Given this list of marker genes RUNX1, CREBBP, CSF2, LGALS3, CBFB, PRKCB, RUNX2, here is a description of the gene set: RUNX1 regulates transcription of genes involved in differentiation of myeloid cells Human Gene Set: REACTOME_RUNX1_REGULATES_TRANSCRIPTION_OF_GENES_INVOLVED_IN_DIFFERENTIATION_OF_MYELOID_CELLS studied in species Homo sapiens